Given this list of marker genes VANGL2 (VANGL planar cell polarity protein 2), WNT5B, MKKS, DVL2, NPHP3, DVL1, LBX2, SFRP1 (NCBI Gene Id 6422), here is a description of the gene set: The morphogenetic process in which an epithelium narrows along one axis and lengthens in a perpendicular axis usually resulting in the formation of the three primary germ layers, ectoderm, mesoderm and endoderm. studied in species Homo sapiens Human Gene Set: GOBP_CONVERGENT_EXTENSION_INVOLVED_IN_GASTRULATION